The following is a description of a gene set: studied in species Homo sapiens RSV-host interactions Human Gene Set: REACTOME_RSV_HOST_INTERACTIONS, and this is the list of marker genes: UBC, BCAP31, MED14, MED7, IFNA17, MED11, RBX1, IFNA5, IFNA1, MED17, CLEC4M, UBE2L6, TLR3, SDC4, IFNA2, STAT2, MED30, LY96, MED31, ISG15, IFNA14, IFNA21, MED26, JAK1, SDC2, TLR6, MED13, MED20, GPC4, MED19, MED27, RPS27A, CX3CR1, MED4, CCNC, GPC2, MED10, MED13L, TLR4, GPC3, IRF3, MED29, MED6, MED15, UBA52 (NCBI Gene Id 7311), SDC1, IFNAR1, IFNA4, TYK2, TLR2, UBB, CD209, CUL5, AGRN, MED23, ELOC, OAS2, GPC6, IFIH1, TLR7, MED9, RIGI, MED18, MED1, MED8, EP300, IFNA13, MED25, H2BC15, HSPG2, IFNA6, IFNA8, GPC1, MED28, SDC3, ARIH1, ELOB, CDK19, MED24 (mediator complex subunit 24), TRIM25, MAVS, MED12, IFNAR2 (NCBI Gene Id 3455), MED21, EIF2AK2, GPC5, IFNA10, IFNA7 (interferon alpha 7), MAP1B, MED16, HERC5, MED22, CD14, CDK8, IFNA16, CREBBP, BECN1, IFNB1 (interferon beta 1)